Given this list of marker genes SLC44A1, QDPR, TSPAN2, GATM, CNTN2, ACTC1, ERMN, CSRP1, CERS2, MCAM, S1PR5, PCYT2, SCD (stearoyl-CoA desaturase), MAG, HMGCS1, MYRF, NPC1, TMBIM6 (NCBI Gene Id 7009), GJB1 (gap junction protein beta 1), CD81, CRYAB, EEF2 (NCBI Gene Id 408221), GSN, OLIG2, ARHGEF10, MAP2K6, SGK1, SYT11, OMG, TALDO1, SERPINB1, SERINC5, TTYH2, MOBP, NDRG1, GLTP, TMEM88B, MAL, CLIC4, FA2H, TMEM63A (NCBI Gene Id 9725), PACS2, PLEKHB1, DAAM2, RNF13, CA2, MBP, WSCD1, SEPTIN4, FABP5, ANLN, GJE1, SLC48A1, MOG, AATK, OLIG1, HCN2, MTRR, QKI, PEX2, PLEKHG3, TPPP3, FRMD4B, S100A16, CCP110, CNP, SOX10, ABCA2, NRBP2, SELENOP, UGT8, GPR37, PTGDS, OPALIN, ARRDC3, APOD, here is a description of the gene set: studied in species Mus musculus Molecular approaches to understanding the functional circuitry of the nervous system promise new insights into the relationship between genes, brain and behaviour. The cellular diversity of the brain necessitates a cellular resolution approach towards understanding the functional genomics of the nervous system. We describe here an anatomically comprehensive digital atlas containing the expression patterns of approximately genes in the adult mouse brain. Data were generated using automated high-throughput procedures for in situ hybridization and data acquisition, and are publicly accessible online. Newly developed image-based informatics tools allow global genome-scale structural analysis and cross-correlation, as well as identification of regionally enriched genes. Unbiased fine-resolution analysis has identified highly specific cellular markers as well as extensive evidence of cellular heterogeneity not evident in classical neuroanatomical atlases. This highly standardized atlas provides an open, primary data resource for a wide variety of further studies concerning brain organization and function. from publication Lein ES, Hawrylycz MJ, Ao N, Ayres M, Bensinger A, Bernard A, Boe AF, Boguski MS, Brockway KS, Byrnes EJ, Chen L, Chen L, Chen TM, Chin MC, Chong J, Crook BE, Czaplinska A, Dang CN, Datta S, Dee NR, Desaki AL, Desta T, Diep E, Dolbeare TA, Donelan MJ, Dong HW, Dougherty JG, Duncan BJ, Ebbert AJ, Eichele G, Estin LK, Faber C, Facer BA, Fields R, Fischer SR, Fliss TP, Frensley C, Gates SN, Glattfelder KJ, Halverson KR, Hart MR, Hohmann JG, Howell MP, Jeung DP, Johnson RA, Karr PT, Kawal R, Kidney JM, Knapik RH, Kuan CL, Lake JH, Laramee AR, Larsen KD, Lau C, Lemon TA, Liang AJ, Liu Y, Luong LT, Michaels J, Morgan JJ, Morgan RJ, Mortrud MT, Mosqueda NF, Ng LL, Ng R, Orta GJ, Overly CC, Pak TH, Parry SE, Pathak SD, Pearson OC, Puchalski RB, Riley ZL, Rockett HR, Rowland SA, Royall JJ, Ruiz MJ, Sarno NR, Schaffnit K, Shapovalova NV, Sivisay T, Slaughterbeck CR, Smith SC, Smith KA, Smith BI, Sodt AJ, Stewart NN, Stumpf KR, Sunkin SM, Sutram M, Tam A, Teemer CD, Thaller C, Thompson CL, Varnam LR, Visel A, Whitlock RM, Wohnoutka PE, Wolkey CK, Wong VY, Wood M, Yaylaoglu MB, Young RC, Youngstrom BL, Yuan XF, Zhang B, Zwingman TA, Jones AR (PMID 17151600) Human Gene Set: LEIN_OLIGODENDROCYTE_MARKERS Genes enriched in oligodendrocytes in the adult mouse brain identified through correlation-based searches seeded with the oligodendrocyte cell-type specific gene expression patterns.